The following is a description of a gene set: from publication Chen Y, Wang X (PMID 31504780) Mouse Gene Set: MIR_467B_5P Genes predicted to be targets of miRBase v22 microRNA mmu_miR_467b_5p in miRDB v6.0 with MirTarget v4 prediction scores > 80 (high confidence targets). studied in species Mus musculus, and this is the list of marker genes: Os9, Jmy, Mbnl3, Aldh1b1, Farp2, Ubxn8, Parp8, Stxbp5l, Nat3, Grb10, Cpeb1, Kcnd2, Prkd3, Man1c1, Mtbp, Casd1, Rorb, Tapt1, Sp3, Yod1, Kdm1b (lysine (K)-specific demethylase 1B), Ankib1, Ikzf2, Mup10, Elavl2, Elk4, Mylk, Mup1, Mettl21c, Erbb4, Lcorl, Lrp2, Kif5b, Rictor, Mup16 (NCBI Gene Id 100039177), Foxf2, Cntn3, Zfhx4, Arhgap6, Nfx1, Slain1, Rnf216, Larp4, Wdr1, Adam23, Mup7, Setbp1, Zbtb41, Fmr1, Nol7, Mup9, Cnot6l (CCR4-NOT transcription complex, subunit 6-like), Mup15, Tox3, Mup18, Kbtbd2, Caprin2, Cldn34c1, Suv39h1, Arid4b, Phc3, Snx5, Mup3, Mup11, Mup2, Fzd6, Itgb4, Cd109 (NCBI Gene Id 235505), Mup20, Hs3st3b1, R3hdm1, Abhd3, Neurl4, Actl6a, Hif1an, Spop, Mybl1, Mab21l4, Tgfbr2, Myocd, Btg1, Mpc1, Znrf3, Synpo2, Ube3a, Mup12, Lats2, Ago1, Tfap4, Ncoa7, Rtn1, Mapk1, Cdk2, Myrf, Prdm4, Pcdhb3, Mup13, Thsd7a, Mup14, Prdm8, Gcc2, Tnrc18, Vwde, Garem1, Hipk3, E2f2, Setd5, Skida1, Nipa1 (non imprinted in Prader-Willi/Angelman syndrome 1 homolog (human)), Fam107b, Irf2bp2, Arhgap29, Lclat1, Ssr1, Tnf (NCBI Gene Id 21926), E2f7, Hivep2, Snrk, Zfp11, Yaf2, Mtmr4, Arx, Taf9b, Pde12, Smarcc2, Jakmip1, Fgf9, Cdkl4, Sorbs2, Arhgap24, Khdc1a